Given this list of marker genes Ank (NCBI Gene Id 52488), Slc25a23, Ucp2, Slc17a8, Slc37a4, Slc17a7, Slc25a24, Xpr1, Slc25a10, Slc34a1, Slc17a6, Slc25a25, Slc37a2 (NCBI Gene Id 56857), Slc20a1, Slc34a3, Slc17a1, Slc34a2, Slc25a3, Slc20a2, Slc37a1, here is a description of the gene set: studied in species Mus musculus Mouse Gene Set: GOMF_PHOSPHATE_TRANSMEMBRANE_TRANSPORTER_ACTIVITY Enables the transfer of phosphate ions from one side of a membrane to the other, up its concentration gradient. The transporter binds the solute and undergoes a series of conformational changes. Transport works equally well in either direction and is driven by a chemiosmotic source of energy. Secondary active transporters include symporters and antiporters.